The following is a description of a gene set: Using killer cell lectin-like receptor G1 as a marker to distinguish terminal effector cells from memory precursors, we found that despite their diverse cell fates both subsets possessed remarkably similar gene expression profiles and functioned as equally potent killer cells. However, only the memory precursors were capable of making IL-2 thus defining a novel effector cell that was cytotoxic, expressed granzyme B, and produced inflammatory cytokines in addition to IL-2. This effector population then differentiated into long-lived protective memory T cells capable of self-renewal and rapid re-call responses. Mechanistic studies showed that cells that continued to receive antigenic stimulation during the later stages of infection were more likely to become terminal effectors. Importantly, curtailing antigenic stimulation towards the tail-end of the acute infection enhanced the generation of memory cells. These studies support the decreasing potential model of memory differentiation and show that the duration of antigenic stimulation is a critical regulator of memory formation Human Gene Set: GSE10239_MEMORY_VS_KLRG1INT_EFF_CD8_TCELL_UP Genes up-regulated in comparison of memory CD8 T cells versus effector CD8 T cells KLRG1 intermediate. from publication Sarkar S, Kalia V, Haining WN, Konieczny BT, Subramaniam S, Ahmed R (PMID 18316415) studied in species Homo sapiens, and this is the list of marker genes: TAF12, SLC22A18, RPL27A, AP5S1, CNRIP1, ZNF444, RPS14, MYCBPAP, GREB1, KLF1, RPL7, FGFRL1, PTX4, PLCD1, SNX2, ZSWIM5, DYNLRB1, RSRP1, SOBP, RPL27, RPS7, NTN5, IFT56, UQCR10, AIPL1, IQCA1, RPL9, IRF2BP2, PRRC2C, SFTPB, TMEM25, PLEKHM3, CNR2, EXOC4, HS1BP3, LYPLA2, PDGFRB, NPFF, TCF7L1, DDR1, CHIA, ATP5MC2 (NCBI Gene Id 517), AJAP1 (adherens junctions associated protein 1), CCND2, SIGLEC1, SCT, PCID2, NPC1L1, SLC9A5, TNFRSF10A, SNHG12, TRIM39, C16orf78, FHIT, FBXO32, C9orf50, ZNF260, ZC3H13, TAFA3, TREML2, KCNJ11, ZNF318, DENND1A (NCBI Gene Id 79878), DTD2, ESYT2, IGLL1, URM1, BIVM, ZNF276, ATXN7L2, PDLIM1, RAMAC, SDHC, SNAP23, CENATAC, TRAF1, TMEM42, TIGD5, RUNDC1, HCAR1, RPS6KA1, MBD2, RGS9, GPBP1L1, SATL1, NMI, SPAG7, FLOT1, NPR1, SLC25A47, CCDC71, LTB, RPL36A, MRPS34, TXNIP, UBOX5 (U-box domain containing 5), PAXX (PAXX non-homologous end joining factor), PTPN1, LURAP1, RREB1 (ras responsive element binding protein 1), MED13L, CLCF1, CLEC16A, MROH2A, RPL18A, KDM2A, SEMA3A, IL10RB, TRPM6, SHISA3, RHD, DUSP8, CLIP4, NTRK2, SCLY, POTEH, PTBP1, TGM3, DLGAP4, SCML4 (NCBI Gene Id 256380), IGSF9B, CSF2RA, SFRP1, SLC6A3, CCNL1, LRTM1, FCGR1A, HOXA9, HIPK2, CLEC4F, ZBTB39, RNF167, CNOT6L, IQCC, SNORC, ELANE, EPS8L3, SON, ZNF335, TMEM213 (transmembrane protein 213), NACC1, PTPN22, AQP12A, MYLIP, CIMIP1, NDOR1, DIS3L2, NFE2L3, FSCN1, ABI1, MPPED1, ADAM33, R3HCC1L, LRRC56, ALB, CAMK1G, FHOD1, TM2D1, ATP6V1C2, CIMIP5, NPRL3, METAP1D, RHCG, C1QTNF12, GPIHBP1, ZBTB8OS, KIF9, LRRC61, DACT2, CBL, SYNDIG1, CMC1, PRDM14, EGR3, GP1BB, MAP2K2, SH3RF3, MCTS1, CARMIL2, DDX5, LRRC75B, SOX14, SNORD123, TBC1D12, WNT7B (Wnt family member 7B), GSE1, TLE6, AKT1S1, UBTD1, TCP11L2, ZNF385C, NPPA, A1CF, TGFB1I1, GPX3, TAF1B, AP2A1, COTL1, CDC26, CXorf38